The following is a description of a gene set: studied in species Homo sapiens Human Gene Set: GOBP_TRIGLYCERIDE_RICH_LIPOPROTEIN_PARTICLE_REMODELING The acquisition, loss or modification of a protein or lipid within a triglyceride-rich lipoprotein particle, including the hydrolysis of triglyceride by lipoprotein lipase, with the subsequent loss of free fatty acid, and the transfer of cholesterol esters to a triglyceride-rich lipoprotein particle by cholesteryl ester transfer protein (CETP), with the simultaneous transfer of triglyceride from a triglyceride-rich lipoprotein particle., and this is the list of marker genes: APOH, LCAT, ANGPTL3, APOA5, NR1H4, APOA4, APOA2, APOA1, APOC3, ANGPTL4, LIPC, CETP, LPL (lipoprotein lipase), APOE, APOC2, GPIHBP1